Given this list of marker genes TOP2A, SMC4, PPP2CA, NCAPH2, NCAPD2 (NCBI Gene Id 9918), PPP2R5C, NCAPD3, PPP2R5A, PPP2R1B, KIF4A, PPP2R5B, PPP2R5E, PPP2CB, NCAPH, NCAPG2, PPP2R5D, PPP2R1A, SMC2, DNMT3B, NCAPG, here is a description of the gene set: species: Homo sapiens Pathway Definition from KEGG: PP2A == Condensin_II -> TOP2A+KIF4A+DNMT3B == Condensin_I Human Gene Set: KEGG_MEDICUS_REFERENCE_CONDENSIN_LOADING Condensin loading. Pathway ID: N01497. Pathway type: Reference. Pathway class: nt06512 Chromosome cohesion and segregation.